Given this list of marker genes PHC3, MAP3K8 (mitogen-activated protein kinase kinase kinase 8), ATL1, FGD3, TCTN3, PRTFDC1, TRIM62, TPRG1L, WBP4, KDM6A (NCBI Gene Id 7403), STT3B, BSDC1, GTF2I, ZNF697, RPS6KB1, EPC1, PABIR3, SERTAD2 (NCBI Gene Id 9792), NDST1, IL3, TMEM254, DCAF7 (NCBI Gene Id 10238), DDX10, CDKL2, SRSF10, IFNGR1, SPIN1 (spindlin 1), DISC1, ARX, DLG5, CIPC, KIAA1217, PRPF38A, TNFSF13B, LYVE1, AMOTL2 (NCBI Gene Id 51421), SLC32A1, RIMBP2, YAF2, PAX5, SLC25A28, RTN1, TOX3, CEMIP2, BRWD1, TRIM33, SESTD1, OSBPL9, SRRM1, DYNC1I1, MFSD6, PIK3CA, SLC2A12, CDKN1C, here is a description of the gene set: from publication Chen Y, Wang X (PMID 31504780) studied in species Homo sapiens Human Gene Set: MIR3914 Genes predicted to be targets of miRBase v22 microRNA hsa-miR-3914 in miRDB v6.0 with MirTarget v4 prediction scores > 80 (high confidence targets).